Given this list of marker genes SCN4A, DOK7, AGRN, NEB, COL6A2, COL13A1, RNASEH1, KBTBD13, CHRND, FLNC, SELENON, RRM2B, SPTLC1, TTN, TNNT1, COL6A3, DES, TPM2, TRIM32, CHRNA1, PLIN4, CHRNE, DYSF, ALS2, AK9, MYH7, LMOD3, RAPSN, POLG, KLHL41, MUSK, LAMA2, MEGF10, CNBP, TOP3A, SIGMAR1, CHCHD10, GYG1, LRP4, SPG11 (NCBI Gene Id 80208), CFL2, FUS, ACTA1, CAV3, SGCG, CHRNB1, here is a description of the gene set: Human Gene Set: HP_NECK_FLEXOR_WEAKNESS species: Homo sapiens Weakness of the muscles involved in neck flexion (sternocleidomastoid, longus capitus, longus colli, and scalenus anterior). Neck flexor weakness